Given this list of marker genes Cyp1a1, Cyp3a41b, Cyp2e1, Cyp3a44, Cyp3a41a, Cyp3a16 (cytochrome P450, family 3, subfamily a, polypeptide 16), Cyp3a11, here is a description of the gene set: The covalent attachment of a hydroxyl group to one or more fatty acids in a lipid. species: Mus musculus Mouse Gene Set: GOBP_LIPID_HYDROXYLATION